The following is a description of a gene set: Human Gene Set: GOCC_CYTOPLASMIC_SIDE_OF_MITOCHONDRIAL_OUTER_MEMBRANE The external (cytoplasmic) face of the mitochondrial outer membrane. species: Homo sapiens, and this is the list of marker genes: LRRK2, BECN1, GRK2, QTRT1, QTRT2